The following is a description of a gene set: Human Gene Set: HP_ABNORMALITY_OF_THE_THYROID_GLAND An abnormality of the thyroid gland. Abnormality of the thyroid gland studied in species Homo sapiens, and this is the list of marker genes: NSDHL, PAX8, GTF2IRD1, GNB1, SMARCAL1, SMO, RNASEH2B, EXOSC2, DIO1, SUFU, BUB3, BUB1, HLA-DQB1, TONSL (NCBI Gene Id 4796), MT-CO1, TTC7A, SPIB, RNASEH2C, ALG8, NPHS1, OPA1, TRHR, CLCNKB, FOXP3, SOX4 (NCBI Gene Id 6659), KISS1R, XRCC4, PI4KA, TRH, SAA1, DCLRE1C, SEMA4A, PTEN, SIX3, NLRP1, IRF4, RPS20, BCL10, SLC25A4, MCM8, GATA4, ADCY5, ABCC8, MSH6, DNM1L, KANSL1, TMEM270, BICRA, CEP57, CDKN1C, MSTO1, DNAH1, RBM28, SECISBP2, CASP10, BCOR, MDM4, OCA2, GTF2I, TRMT10A, SOX11, BBS2, CEP19, SRY, POU1F1, FGF13, USP9X, POLD1, MT-ND5, LHX3, IFIH1, MPV17, CRELD1, NF1, FASLG, SLC25A36, EIF2AK3, GLI2 (GLI family zinc finger 2), SMARCC2, ARID2, CTNNB1, SLC26A4 (NCBI Gene Id 5172), TERT, POLE (NCBI Gene Id 80252), ARID1B, KCNJ10, CCBE1, HGD, CDON, UBE4B, MMP23B (NCBI Gene Id 8510), PIK3CA, USF3, TBX1, DNAJC30, TNFSF15, BUB1B, TBCK, IRF5, SLF2 (NCBI Gene Id 55719), VPS37D, HBB, YRDC, GYG1, B4GALT1, TRIM32, BAZ1B, KARS1, ATP5F1E, PLAAT3 (NCBI Gene Id 11145), ATP5F1D, MRAP, MALT1, NDUFB11, CDKN2C, BMP4, MT-TL1, SHH, NF2, SDHB, FARSA, NRAS, DNAJC19, GNB2, CLPB, KCNJ11, ATP5MK, LIMK1, IGF2, ATP8B1, MPI, BBS10, LEP, MT-TW, GLI3, EYA1, CPE, GRM7, POU3F4, CDKN2A, C1S, POLR3A, IPO8, MT-TF, METTL27, PRKAR1A, DPF2, BIRC3, PNPLA6, WFS1, ARID1A (AT-rich interaction domain 1A), LIFR, PROKR2, IFT172, GNE, FGFR1, LIG4, TIAM1, SLC12A3 (solute carrier family 12 member 3), LRBA, NR1H4, ACP5, TG, ADA2, KCNAB2, FOXA2, FOXN1, FANCI, CTLA4, KMT2B, WRN, TREX1, FLCN, TPO, IGSF1, LUZP1, ABCB11, MEN1, THRB, MT-ND4, MT-ATP6, GPR101, GREM1, ARL6, HMGA2, IFT74, C1QBP, TSC2, SOX3, FOXI1, UFD1, MMEL1, KLF1, IRS4, CHD6, ATP5F1A, PIEZO1, PRDM10, SCLT1, BMP6, LSM11 (NCBI Gene Id 134353), MSH3, JAG1, SKIC2, SKIC3, GAS1, LRP4, KMT2D, SDCCAG8, DICER1, CDC73, ADA, SRD5A3, PIK3C2A, SKI, MT-CO3, ZBTB20, BBIP1, TBL2, MT-TQ, TTC8, TRAPPC9, GRIN2B, MADD, SGPL1, TXNRD2, WDPCP, RERE, CHD7, LHX4, SASH1, IL12RB1, GNAS (GNAS complex locus), MT-ND1, FOCAD, POLR1B, PMM2, MT-ATP8, RNU7-1, FUCA1, ALG2, GLIS3, BBS4, SIX1, ROBO1, SPEN, NODAL, ADAR, SPOP, SLC6A17, IL7R, MYT1L, BTNL2, EIF4H, GABRD, MID1, HYMAI, FGF8, NIN, EXT2, COMT, RAG2, PDPN, IMPDH2, ATM, FOXD3, TBC1D24, CHD8, GRIA1, RNASEH2A, SLC16A2, POLR1C, RAG1, MDM2, PLVAP, MMP2, CBLB, HESX1, GCH1, SEC23B, JAK1, SCN4A, SIM1, JMJD1C, RCBTB1, PTRH2, SEC24C, ELN, MT-TH, ITCH, NKX2-5, KRAS, STIL, STAG2, NR4A2, RMRP, GNAQ, POLR3GL, ADAT3, MKS1, TCOF1, POU2AF1, MKKS, CREBBP, PROP1, NFKB2, BBS12, KCNJ2, HFE, ARL6IP6 (NCBI Gene Id 151188), BMPR1A, FAS, STEAP3, RNU4-2, MLH1, PHF21A (NCBI Gene Id 51317), FDX2, HPD, DUOXA2, BAP1, IL18BP, MLXIPL, DMXL2, PDE4D, PLAG1, MT-ND6, FUT8, CFAP418, AIP, HLA-DRB1, ZIC2, HSPG2, LZTFL1, PLAGL1, INSR, RAI1, SEMA4D, SDHC, MMP14, AKT1, NCF1, TBX2, HNF1B, PCSK1, WDR4, PDCD1, FKBP6, TGFBR2, FLII, POLG, POLG2, CDKN1A, TTR, ALMS1, NNT, HR, GP1BB, BBS5, TCF4, ARVCF, GTF2IRD2, PDE11A, ALB, SMARCE1, TF, POMC, HDAC4, AFF4, TWNK, CCDC47, BBS1, BRAF, EPCAM, KDM6A, FOXH1, PRIM1, HSD17B3, SLC37A4, MT-TL2, GNA11, RPL10, CYP27A1, CNBP, HID1, CACNA1S, MSH2, SMARCB1, PDGFB, CDH23, SVBP, APC, TP53, AIRE, STAT5B, TGIF1, UBR7, IFNG, GABRA3, UBR1, IL12A, TRIP13, B3GLCT, RFC2, NPHP1, MC2R, TRAF7, DUOX2, MT-TN, ADAMTSL1, HEPACAM, ASH1L, CRIPTO, SDHD, STAR, IDH2, SUPT16H, TANGO2, PPP1R15B, POLR1D, SASH3, NKX2-1, PMS2, SMC1A, HIRA, CDKN2B, SUGCT, IL2RG, PRKCZ, SCAPER, IDH1, KEAP1, DACT1, THRA, CTNS, FMR1, MTTP, BBS7, PRDM16, HLA-DQA1, ZFP57, GPR35, PLCH1, KLLN, MARS1, WDR11, KATNIP, SIX2, DISP1, MT-CO2, MINPP1, STAT3, SLC5A5, DDB1, HABP2, IYD, STAT1, BUD23, STUB1, DEAF1, BBS9, SAMHD1, FOXP1, TSC1, TSHB, SOCS1, KAT6B, CASZ1, ZFAT, MAGEL2, MOGS, SNRPN, APOE, CDKN1B, CHEK2, DYRK1A, TRPV6, MUTYH, NDN, TMEM67, APC2, TSHR, CASR, CLIP2, SMARCD1, RRM2B, SETBP1, SRGAP1, SMARCA4, ATPAF2, LEPR, HRAS, DDOST, PLCG2, ATP6V1B2 (ATPase H+ transporting V1 subunit B2), ATP11A, OTX2, DNA2, ABCB4, NEXMIF, RET, STX1A, KCNJ18 (NCBI Gene Id 100134444), LMNA, DLL1, CEP290, GPR161, TBL1X, IL6ST, PLAA, RREB1, SIX5, CACNA1C, YY1, MST1, FOXE1, GATA6, SALL1 (NCBI Gene Id 6299), IQSEC2, CD55, MT-TS2, ALX4, ZFX, HNRNPK, PTCH1, IL2RA, BRCA2, PMS1, IFT27, TNPO3, ANAPC1, MAD1L1, ARNT2, NSD1